The following is a description of a gene set: part of: Metabolism of proteins electronically inferred by orthology from the curated human pathway This event has been computationally inferred from an event that has been demonstrated in another species.<p>The inference is based on the homology mapping from PANTHER. Briefly, reactions for which all involved PhysicalEntities (in input, output and catalyst) have a mapped orthologue/paralogue (for complexes at least 75% of components must have a mapping) are inferred to the other species. studied in species Mus musculus Reactome Pathway: Mitochondrial protein degradation, and this is the list of marker genes: Acadsb, Eci1, Ndufa13, Atp5pd, Acot5, Fech, Hspd1, Htra2 (NCBI Gene Id 64704), Clpp, Arg2, Afg3l2, Tfam, Ndufs3, Oxct1, Slc25a5, Prkaca (NCBI Gene Id 18747, protein kinase, cAMP dependent, catalytic, alpha), Smdt1, Clpx, Uqcrc2, Atp5pf, Acad8, Pdha1, Aldh1b1, Atp5f1b, Idh2, Cox5a, Ndufa2 (NADH:ubiquinone oxidoreductase subunit A2), Mdh2, Fh1, Atp5po, Acot2, Dld, Glud1, Ndufv3, Aldh2, Bdh1, Ech1, Acot3, Mrpl32, Lonp1